Given this list of marker genes Tnip3, H1f1, Ptger4, H1f4, Zfpm2, Gpr39, Ascc3, H3c6, Gpr183, Gli1, Angpt4, Coch, H3c7, Esr2, H2ac15, Slc6a19, Mmp28, Dynap, H2-M3, Colec12, Scin, Bmp4, Nrp1 (neuropilin 1), Htr2b, Cdhr1, Insrr (insulin receptor-related receptor), Cpa4, A2m (alpha-2-macroglobulin), Ephb2, H2-DMb2, Parp9, Golga7b, Amotl2, Atp2b4 (ATPase, Ca++ transporting, plasma membrane 4), Capns2, H2bc6, H3c2, Cryba4, Snx7, Acot9, Tlr2, Pde4d, H4c16, Podnl1, Fam20a, Lrrc4, Nbl1, Wnt11, H4c11, H4c6, H1f2, H4c3, Esyt1, Pcsk5, Gsdma, Nuak1, Adgrf5, Ccn5, Adgrg7, H2ac6, Krtap1-5, Adam12, Casp12, Slc24a3, Angpt1, Spon1 (NCBI Gene Id 233744), H2bc15, Tnc, Col5a2, Gdpd2, Chst4, Hivep2, Fzd1, Col8a1, H4c4, Aldh3b3, Plekhg4, Serpinb9, Lox, Slc25a48, Vps13c, Cxcr6, Ccn4, H2bc7, Btnl2, Large1, H3c1, Slc4a4, Glis3, H1f5, Plaat3, Cd101, Gbp2, Pi15, H2bc14, Adam4, Adamts12, Edn1, H3c10, Apol10b (NCBI Gene Id 328561), Bbox1, Ly75, Cyld, Vopp1, Csmd3, Plscr2, H2-Q4, Tent5a (terminal nucleotidyltransferase 5A), Brinp3, Psmb8, Ccl1, Lrrc15, Vcam1, Cacna1e, Slc6a20a, Bst1, Ogn, H1f3, Tmem150b, Tnfrsf1b, Mospd2, Ncam1 (neural cell adhesion molecule 1), H2bc8, Tifa, Jakmip1, Rnf19b, Slc9a4, Creb3l1, Slc12a1, Pcdhgb5, Tgfbr2, Gbp7, Ankrd1, Foxn1, Idi2, H2bc11, H3c3, H2bc3, Hspa4l, H2bc9, Prdm1, Cfh, H2ac19, Skil, Itgb8, H4c1, Krt86, Lif, H2bc18, Clec5a, Gsap, Ly6m, Slc8a1, Pcdhga8, Gbp3, Ell2, Nrp2, Runx3, Wnt9a, Apol9b, Fgd3, Prr9, H4c2, Usp53, Upk3bl, Ulbp1, H2-Eb2, Zic1, Apol9a, Alox12b, Fa2h, Msln, Tmprss11f, H3c15, Pcdhga9, Hephl1, B3galt2 (NCBI Gene Id 26878), Plcg2 (NCBI Gene Id 234779), Ace2, Rasa4, St8sia4, Arhgap29, Col1a2, Bmp8a, C1qtnf3, Pla1a, Crabp2, Ikzf2, Col12a1, Cthrc1, Popdc3, Scn3a, Ust, Notch2, Il13ra1, Il12rb1, Sp8, Rspo2, Cp, Fndc7, here is a description of the gene set: studied in species Mus musculus Mouse Gene Set: ZENG_GU_ICB_CONTROL_METAGENE_14_PRECICTIVE_ICB_RESPONSE Most patients with cancer are refractory to immune checkpoint blockade (ICB) therapy, and proper patient stratification remains an open question. Primary patient data suffer from high heterogeneity, low accessibility, and lack of proper controls. In contrast, syngeneic mouse tumor models enable controlled experiments with ICB treatments. Using transcriptomic and experimental variables from >700 ICB-treated/control syngeneic mouse tumors, developed a machine learning framework to model tumor immunity and identify factors influencing ICB response. Projected on human immunotherapy trial data, found that the model can predict clinical ICB response. further applied the model to predicting ICB-responsive/resistant cancer types in The Cancer Genome Atlas, which agreed well with existing clinical reports. Metagene derived from the control samples, found to be predictive of immune checkpoint blockade treatment response, not otherwise discussed. from publication Zeng Z, Gu SS, Wong CJ, Yang L, Ouardaoui N, Li D, Zhang W, Brown M, Liu XS (PMID 36240281)